The following is a description of a gene set: studied in species Homo sapiens Human Gene Set: HP_JOINT_SUBLUXATION A partial dislocation of a joint. Joint subluxation, and this is the list of marker genes: GLB1, ARSL, TNXB, RMRP, RIGI, IDUA, MMP2, COL5A1, ADAMTS2, FLNB, COL2A1, KIF22, LTBP1, B3GALT6, CHD7, PUF60 (NCBI Gene Id 22827), BPNT2, DCHS1, GNPTAB, IFIH1, GLI3, COL1A2, FBLN5, XYLT1 (NCBI Gene Id 64131), GALNS, DDR2, EFEMP2, PLOD1, COL1A1, MADD, HNRNPH1